Given this list of marker genes CHEK2, RNF43, MLH1, KEAP1, MSH6, SEMA4A, AKT1, PTEN, BMPR1A, KLLN, CDKN2A, AXIN2, TP53, SMAD4, KIT, PDE11A, SEC23B, MSH2, POLD1, STK11, POLE (NCBI Gene Id 80252), MUTYH, NTHL1 (NCBI Gene Id 4913), KRAS, PMS2, RPS20, DICER1, GREM1, PRKAR1A, TGFBR2, ATM, PIK3CA, PDGFRA, MSH3, ENG, USF3, BRCA2, MDM2, SDHB, SDHC, SDHD, EPCAM, PMS1, SDHA, APC, here is a description of the gene set: Human Gene Set: HP_NEOPLASM_OF_THE_RECTUM species: Homo sapiens Neoplasm of the rectum